Given this list of marker genes CXCL8, COL7A1, SCG5, TMEM158, ANGPTL4, PGK1, CXCL3, SLC16A3, CXCL6 (C-X-C motif chemokine ligand 6), NAMPT (nicotinamide phosphoribosyltransferase), IL24, PTGES, PLIN2, IL11, WNT5A, CD82, MT1E, TNFAIP6, CCL2, G0S2, STC1, EGLN3, DDIT4, VEGFA, AKR1B1, SOD2, UPP1, CA12, MMP3, CXCL2, BNIP3 (BCL2 interacting protein 3), FAM162A, MMP1, STEAP1, SERPINE1, IGFBP3, NDRG1, HILPDA, IER3, ENO1, CXCL5, CHI3L1, CXCL1, MT2A, MME, C15orf48, INHBA, ADM, IL6, PLAU, here is a description of the gene set: studied in species Homo sapiens from publication Gavish A, Tyler M, Greenwald AC, Hoefflin R, Simkin D, Tschernichovsky R, Galili Darnell N, Somech E, Barbolin C, Antman T, Kovarsky D, Barrett T, Gonzalez Castro LN, Halder D, Chanoch-Myers R, Laffy J, Mints M, Wider A, Tal R, Spitzer A, Hara T, Raitses-Gurevich M, Stossel C, Golan T, Tirosh A, Suvà ML, Puram SV, Tirosh I (PMID 37258682) In this study, an extensive analysis was conducted to define meta-programs (MPs) capturing intra-tumor heterogeneity across a spectrum of tumor types. The approach utilized non-negative matrix factorization (NMF) to analyze each cell type separately within individual tumor samples. This involved the analysis of malignant cells, macrophages, fibroblasts, endothelial cells, epithelial cells, T-cells, and B-cells. NMF was executed with varying parameter values (K=4, 5, 6, 7, 8, 9), thereby generating 39 programs for each cell type per sample. Each NMF program was summarized by the top genes based on NMF coefficients.\nRobust MPs were then delineated for each cell type using a set of stringent criteria, including recurrence within the same tumor, similarity to programs in other tumors, and non-redundancy within a tumor. Subsequently, these robust NMF programs were clustered (per cell type) based on Jaccard similarity, leading to the identification of MPs associated with each cell type.\nTo enhance the quality of the MPs, a refinement steps were undertaken, involving the removal of MPs suspected of reflecting low-quality data (with an overrepresentation of ribosomal proteins or mitochondrial-encoded genes), single-study inclusion, or similarity to miss-annotated cell types. Genes upregulated in subsets of cells of a given type within various tumors Human Gene Set: GAVISH_3CA_METAPROGRAM_FIBROBLASTS_HYPOXIA